The following is a description of a gene set: Human Gene Set: GOMF_LIPASE_ACTIVATOR_ACTIVITY Binds to and increases the activity of a lipase, an enzyme that catalyzes of the hydrolysis of a lipid. studied in species Homo sapiens, and this is the list of marker genes: PLAA, FYN, CCL8, APOA5, APOC2, PDGFRB, ARHGAP6, BTK, ARL1, CCL3, ABHD5, HRAS, CASP3, PDPK1, SRC, APOH, ARF4, GPIHBP1, LCK, GM2A, PDGFRA, CCL5, STX4